Given this list of marker genes Epha10 (Eph receptor A10), Raf1, Pak1, Kdr, Erbb2, Mtcl2, Rps6kb2, Ogt, Ffar3, Egfr, Irs3, Prkcd, Eif4ebp2, Inpp5k, Epha2, Enpp1, Foxo4 (forkhead box O4), Rbx1, Zfp592, Mzb1, Ptpre (NCBI Gene Id 19267), Epha4, Ltk, Mertk, Srsf3 (serine and arginine-rich splicing factor 3), Mapk3, Shc1, Tie1, Sesn3, Prkcb, Mup3, Grb7, Hmga1, Foxc2, Marcks (NCBI Gene Id 17118), Mst1r, Slc39a14 (solute carrier family 39 (zinc transporter), member 14), Cul7, Kit, Flt3, Akt1, Alk, Apc, Ntrk1, Tek, Rarres2, C2cd5, Csf1r, Ncoa5, Mup5, Mup11, Ptprj, Mir143, Epha1, Prkcz, Sik2, Pdpk1, Pdk2, Socs7, Pip4k2c (phosphatidylinositol-5-phosphate 4-kinase, type II, gamma), Gpld1 (NCBI Gene Id 77224), Bcar3, Epha6, Grb10, Pid1, Ephb4, Ephb3, Blvra, Obp2a, Phip, Rhoq, Plcb1, Mir494, Fgfr1, Col6a1, Sorbs1, Vwa2, Irs2, Sos1, Ndel1, Foxo1, Cav2, Nucb2, Tsc2, Tns2 (tensin 2), Ptpn1, Slc27a4, Ror2, Rbm4, Gsk3a, Pik3r3, Erbb4, Gnai2, Ankrd26, Erfe, Src, Mup2, Ephb2, Fgfr4, Slc2a8, Igfbp1, Stxbp4, Epha5, Pdgfrb, Map2k1, Axl (AXL receptor tyrosine kinase), Grb14, Ctsd, Sos2, Eif4ebp1, Socs3 (suppressor of cytokine signaling 3, NCBI Gene Id 12702), Ncl, Inppl1, Kank1, Prkca, Nck1, Serpina12, Irs1, Fgfr3, Tnf, Opa1, C1qtnf12, Blvrb, Hras, Ret, Pik3r1, Nr1h4, Pik3r2, Ahsg, Epha8, Lonp1 (lon peptidase 1, mitochondrial), Nucks1, Sorl1, Pip4k2b, Pip4k2a, Agt, Rps6kb1, Flt1, Prkaa1, Zfp106, Pik3ca, Snx5, Sh2b2, Ins2, Bcar1, Ddr1, Tyro3, Ros1, Socs1 (suppressor of cytokine signaling 1), Musk, Zbtb7b, Ddr2, Gkap1, Rela, Pdk4, Ptpn11, Akt2, Ptpn2, Smarcc1, Trim72 (tripartite motif-containing 72), Mup1, Sirt1, Flt4, Epha3, Fgfr2, Irs4, Gpr21, Fut7 (fucosyltransferase 7), Srebf1, Igf1r, Ntrk2, Gsk3b, Appl1, Pdgfra, Insrr, Adipor1, Mstn, Ide, Il1b, Ptpra, Fbxw8, Ephb1, Ins1, Mup4, Prkcq, Lep, Fer, Dnai1, Mfn2 (mitofusin 2), Insr, Csrp3, Mapk1, Ntrk3, Igf2, Grb2, Epha7, Osbpl8, Met, Ptprf, here is a description of the gene set: studied in species Mus musculus The series of molecular signals generated as a consequence of the insulin receptor binding to insulin. Mouse Gene Set: GOBP_INSULIN_RECEPTOR_SIGNALING_PATHWAY